Given this list of marker genes Amy2a4, Amy2a1, Amy1, Amy2a5, Amy2a3 (amylase 2a3), Mgam, Amy2a2, here is a description of the gene set: Mouse Gene Set: GOMF_AMYLASE_ACTIVITY species: Mus musculus Catalysis of the hydrolysis of amylose or an amylose derivative.